The following is a description of a gene set: from publication Hoek KL, Samir P, Howard LM, Niu X, Prasad N, Galassie A, Liu Q, Allos TM, Floyd KA, Guo Y, Shyr Y, Levy SE, Joyce S, Edwards KM, Link AJ (PMID 25706537) Human Gene Set: HOEK_NEUTROPHIL_2011_2012_TIV_ADULT_1DY_UP Genes up-regulated in neutrophil 1d vs 0d in adults after exposure to 2011-2012 trivalent inactivated vaccine (A/California/7/09 (H1N1), A/Perth /16/2009 (H3N2), B/Brisbane/60/2008), time point 1D. Comment: Up-regulated DE RNA transcripts (up >= 1.5x) shared between both TIV-vaccinated donors Systems biology is an approach to comprehensively study complex interactions within a biological system. Most published systems vaccinology studies have utilized whole blood or peripheral blood mononuclear cells (PBMC) to monitor the immune response after vaccination. Because human blood is comprised of multiple hematopoietic cell types, the potential for masking responses of under-represented cell populations is increased when analyzing whole blood or PBMC. To investigate the contribution of individual cell types to the immune response after vaccination, we established a rapid and efficient method to purify human T and B cells, natural killer (NK) cells, myeloid dendritic cells (mDC), monocytes, and neutrophils from fresh venous blood. Purified cells were fractionated and processed in a single day. RNA-Seq and quantitative shotgun proteomics were performed to determine expression profiles for each cell type prior to and after inactivated seasonal influenza vaccination. Our results show that transcriptomic and proteomic profiles generated from purified immune cells differ significantly from PBMC. Differential expression analysis for each immune cell type also shows unique transcriptomic and proteomic expression profiles as well as changing biological networks at early time points after vaccination. This cell type-specific information provides a more comprehensive approach to monitor vaccine responses. species: Homo sapiens, and this is the list of marker genes: NXT2, RSAD2, IFI44, TFEC, C12orf60, ATF3, PDCD1LG2, ECE1-AS1, EGR2, GBP6, FRMD3, LINC02555 (long intergenic non-protein coding RNA 2555), SNORA11, OAS3, HES4, OAS1, DDX60, SGPP1, SESTD1, P2RY14, HLA-DRA, PRKX, OAS2, LRRK2-DT, CPT1B, MT2A, LINC02471, HLA-DMB (major histocompatibility complex, class II, DM beta), H1-4, IFI44L, HLA-DMA, EPSTI1 (epithelial stromal interaction 1), NRIR, FANCL, XAF1, GCH1, APOL3, DOCK4-AS1